Given this list of marker genes Vegfb, Artn, Fgf10, Cxcl12, Ntf3, Vegfd, Prkca, Hmgb1, Pgf (placental growth factor), Ager, Ccl21a, Vegfa, Il16, Creb3, Vegfc, Scg2, here is a description of the gene set: species: Mus musculus Any process that initiates the directed movement of a motile cell or organism towards a higher concentration in a concentration gradient of a specific chemical. Mouse Gene Set: GOBP_INDUCTION_OF_POSITIVE_CHEMOTAXIS